The following is a description of a gene set: Mouse Gene Set: MIR_6367 species: Mus musculus from publication Chen Y, Wang X (PMID 31504780) Genes predicted to be targets of miRBase v22 microRNA mmu_miR_6367 in miRDB v6.0 with MirTarget v4 prediction scores > 80 (high confidence targets)., and this is the list of marker genes: Mfsd9, Atp11a, Dus1l, Lfng, Trem6l, Itga8, Dennd6a, Nfkbib, Il16, Sgpl1, Arid3a, Orc2, Prdm1, Zdhhc9 (NCBI Gene Id 208884), Sel1l, Tmprss13, Gga2, Gpatch8, Mcl1, Fbxw4 (F-box and WD-40 domain protein 4), Npl, Bmf, Myt1, Tada3, Chtf8, Cdh5, Alg6, Tafazzin, Zfp488, Daam1, Ptpn7, Prdm2, Abcb11, Scn2b, Arid3b, Ist1, Zfp523, Was, Cgref1, Ovol1, Crem, Trim71, Mapre2, Mtf1, Rbm7, Klhl24, Dock3, Zscan29, Cdk16, Gpr153, Sema4c, Ppp4r3a, Map3k10, Zfp518a, Kmt5c, Lrp4, Rufy3, Ikzf4, Nbeal2, Lif, Xirp1, Dynlt3, Casp2, Khnyn (KH and NYN domain containing), Elovl6, Alpk3, Zswim5, Kcnip3, Hapln1, Ccnj, Abhd3, Ino80d, Ceacam1, Galnt14, D17H6S53E, Zbtb34, Ahrr, AU040320, Anpep, Dnajc14, Osgep, Rasgef1a, Hdac3, Nipal4, Abhd6, Pi4k2b, Nup210, Dicer1, Plekhm3 (NCBI Gene Id 98354), Jade2, Pafah1b1, Rbm20, Tnfaip3, Cntd1, Samd10, Eva1a, Pcsk7, Ttc29, Mfsd13a, Ubr7, Nrm, Slitrk6, Phactr3, Eif1ad, Glb1l2, Stard13, Cyyr1, Slc39a9, Necab3, Tmtc2, Fam83h (NCBI Gene Id 105732), Sstr3, Sarm1, 2610528J11Rik, Arrb1, Enpep, Ppat, Fam118a, Nr6a1, Ppp2ca, Zbtb37, Fam234b, Slc6a17, Kctd21, Vps4b, Ppp2r5c, Klf13, Blzf1, Rfxank, Lclat1, Lactb, Vdr, Grhl1, Retreg2, Sptb, Cdk19, Slc25a15, Ier3ip1, Gal3st2, Cbx7, Bnip2, Eif4ebp1, Ninl, Slc35a4, Mobp, Golga5, Rap1a, Ajuba, Tbc1d8b, Tgoln1, Ankrd50, Dhx33, Map3k11, Cgn, Eaf1, Klc2, Cdc42se1, Bap1, Abtb1, Tor2a, Kcnk10, Irf4, Ube2g1, Scarb1, Ier2, Abcc5, Msrb3, Scn4a, Retreg3, Tspan12, Brip1, Grb10, Rhoq, Ppm1h, P2rx4 (NCBI Gene Id 52272), Pcgf6, Plxna1, Tril, Zfyve1, Bak1, Nhsl3, Podxl, Rora, Nkapd1 (NCBI Gene Id 270156), Tmem161b, Ebf4, Rfx3, Cln6, Scgb1b30, Cdc42bpg, Lin28b, Tmem120b, Acer2, Ptpn1, Neu1, Mfhas1, Sh3bp5l, Triap1, Zfp704, Ncan (neurocan), Ercc6l2, Acads, Tmem25, Kcns3 (potassium voltage-gated channel, delayed-rectifier, subfamily S, member 3), Gal3st2c, Sec14l2, Cnnm1, Nim1k, Tle3, Galnt5, Prss33 (serine protease 33), Tnfsf4, Sema4b, Smurf1, Prtg, Cacna1b, Gtpbp2, Sbno1, Hif1an, Cdc37l1, Dram2, Tmem72, Atxn1, Ctnnal1, Ndufs4, Speg, Bet1, Lin28a (NCBI Gene Id 83557), Kcna1, Sh3tc2, Vps37b, Cyp24a1, Tmem132e, Fut1, Sertad3, Tjap1, Diras1, Zbtb7a, Suv39h1, Kbtbd13, Dvl1, Tent5a, Serpinb9d (NCBI Gene Id 20726), Il6ra, Ttc7, Scara5, M6pr, Slc25a35, Gcnt1, Usp38, Rbak, Hic2 (NCBI Gene Id 58180), Bhlhe41, Lrrc10b, Zfp408, Grsf1, Trp53inp1 (transformation related protein 53 inducible nuclear protein 1), Cyth1, Crb2, E2f2, Mlf2, Osbpl9, Tbc1d1, Borcs6, Ulk3, Grk4, Man1b1, Stat3, Sema4d, Lhx8, Bag4, Dtx4, Mamdc2, Zswim6, Cdr2l, Nckap5l (NCK-associated protein 5-like), Frmd5, Syvn1, Shtn1, Nin, Zfp62